Given this list of marker genes LAMA1, ITGA8, DSPP, DAG1, COL5A2, LAMB1, COL4A5, DCN, MATN4, LAMC1, COL6A5, LAMA3, COL4A4, LUM, LRP4 (NCBI Gene Id 4038), TNXB, COL5A1, HSPG2, SPARC, IBSP, COL5A3, LAMA2 (NCBI Gene Id 3908), AGRN, COL4A1, BCAN, HAPLN1, TGFB1, COL4A6, BGN, FN1, ITGAX, COL4A3, ACAN, PTPRS, COL9A3, VTN, TGFB3, TGFB2, COL1A1, TNC, COL9A1, VCAN, ITGAV, TNR, DMP1, APP, ITGA7, COL6A2, LAMB2, COL6A3, ITGB1, ITGA2 (NCBI Gene Id 3673), COL2A1, ITGB5, NCAM1, COL3A1 (NCBI Gene Id 1281), ITGA2B, LAMA4, COL6A1, MATN1, ITGA9, ITGB6, MUSK, ITGB3, TNN, COL1A2, COL9A2, LAMA5 (laminin subunit alpha 5), COL6A6, ASPN, SERPINE1, MATN3, COL4A2, NCAN, COMP, FMOD, here is a description of the gene set: part of: Extracellular matrix organization studied in species Homo sapiens Reactome Pathway: ECM proteoglycans Proteoglycans are major components of the extracellular matrix. In cartilage the matrix constitutes more than 90% of tissue dry weight. Proteoglycans are proteins substituted with glycosaminoglycans (GAGs), linear polysaccharides consisting of a repeating disaccharide, generally of an acetylated amino sugar alternating<br>with a uronic acid. Most proteoglycans are located in the extracellular<br>space. Proteoglycans are highly diverse, both in terms of the core proteins and the subtypes of GAG chains, namely chondroitin sulfate (CS), keratan sulfate (KS), dermatan sulfate (DS) and heparan sulfate (HS). Hyaluronan is a non-sulfated GAG whose molecular weight runs into millions of Dalton; in articular cartilage, a single hyaluronan molecule can hold upto 100 aggrecan molecules and these aggregates are stabilized by a link protein.